The following is a description of a gene set: studied in species Homo sapiens Human Gene Set: MATZUK_CENTRAL_FOR_FEMALE_FERTILITY Genes central for female fertility pathways, based on mouse models with female fertility defects. Reproduction is required for the survival of all mammalian species, and thousands of essential 'sex' genes are conserved through evolution. Basic research helps to define these genes and the mechanisms responsible for the development, function and regulation of the male and female reproductive systems. However, many infertile couples continue to be labeled with the diagnosis of idiopathic infertility or given descriptive diagnoses that do not provide a cause for their defect. For other individuals with a known etiology, effective cures are lacking, although their infertility is often bypassed with assisted reproductive technologies (ART), some accompanied by safety or ethical concerns. Certainly, progress in the field of reproduction has been realized in the twenty-first century with advances in the understanding of the regulation of fertility, with the production of over 400 mutant mouse models with a reproductive phenotype and with the promise of regenerative gonadal stem cells. Indeed, the past six years have witnessed a virtual explosion in the identification of gene mutations or polymorphisms that cause or are linked to human infertility. Translation of these findings to the clinic remains slow, however, as do new methods to diagnose and treat infertile couples. Additionally, new approaches to contraception remain elusive. Nevertheless, the basic and clinical advances in the understanding of the molecular controls of reproduction are impressive and will ultimately improve patient care. from publication Matzuk MM, Lamb DJ (PMID 18989307), and this is the list of marker genes: GGT1, FSHB, EGR1, KISS1R, CDK4, STAT3, GNRH1, KISS1, ACVR2A (NCBI Gene Id 92), PROP1, LEPR, OTX1, POU1F1, AIRE, CGA, TSHB, TGFB1, LEP, GNRHR, LHB, TKT, GHR, DDR2, INSL3, CRTC1, NPR2, AFP, CPE, CDKN1C